The following is a description of a gene set: species: Mus musculus RNA Polymerase II Transcription Termination Mouse Gene Set: REACTOME_RNA_POLYMERASE_II_TRANSCRIPTION_TERMINATION, and this is the list of marker genes: Cpsf1, Sympk, Srsf2, U2af1, Srsf11, Srsf9, Alyref, Srrm1, U2af1l4, Upf3b, Cstf2, Snrpb, Magoh, Cpsf7, Thoc2, Lsm11, Casc3, Papola, Slu7, Cpsf2, Clp1, Srsf5, Thoc3, Rbm8a, Ddx39b, Lsm10, Chtop, Cstf3, Srsf7, Slbp, Pabpn1, Dhx38, U2af2, Snrpg, Ncbp2, Snrpf, Wdr33, Rnps1, Cpsf6, Zfp473, Nudt21, Thoc1, Eif4a3, Ncbp1, Fip1l1, Cstf2t, Thoc6, Snrpd3, Sarnp, Fyttd1, Cdc40, Cpsf3, Snrpe, Cpsf4 (cleavage and polyadenylation specific factor 4), Ddx39a, Srsf3, Pcf11, Zc3h11a, Cstf1, Srsf1, Thoc7, Poldip3